Given this list of marker genes Sgpl1, Ptprn, Nr5a1, Mfn2, Stat5b, 2610005L07Rik, Retn, Schip1, Inhba, Plekha1, Gdf9, A2m, Mmp2 (NCBI Gene Id 17390), Runx1, Stat5a, Fzd4, Pdgfra, here is a description of the gene set: The set of processes resulting in differentiation of theca and granulosa cells into luteal cells and in the formation of a corpus luteum after ovulation. species: Mus musculus Mouse Gene Set: GOBP_LUTEINIZATION